The following is a description of a gene set: species: Mus musculus Mouse Gene Set: REACTOME_EUKARYOTIC_TRANSLATION_INITIATION Eukaryotic Translation Initiation, and this is the list of marker genes: Rps27l, Rpl35a, Rpl23a, Rpl3, Rpl12, Fau, Rps6, Rpl7a, Gm6525, Rpl18a, Rpl13a, Uba52, Rps14 (ribosomal protein S14), Rpl22l1 (ribosomal protein L22 like 1), Rps17, Rpl6, Rps27, Rpl39, Eif4ebp1, Rps7, Eif3k, Rps5, Rps9, Eif3j2, Rpl39l, Rpl37, Eif4a1, Rps24, Rpl27a, Rps11, Rpl18, Rpl34, Eif2s3x, Rps19, Rpl35rt, Eif3g, Rps27rt, Rps4x, Eif3f, Rpl36, Rpl24, Rps23, Eif3d, Rps29, Rps21, Rpl32 (ribosomal protein L32), Rpl31, Rps13, Eif3m, Eif1ax, Rps28, Eif2s1, Rpl23, Eif4g1, Eif2b2, Rpl27, Rpl9, Rpl10-ps3, Rpl36a-ps1, Rpl35, Rpl37a, Eif4a2, Eif5, Eif4h, Rps15a, Rpl30, Rplp1, Rpl5, Rplp0, Rps25, Rpl13, Eif4b (NCBI Gene Id 97980), Rps27a (ribosomal protein S27A), Eif3j1, Eif3h, Rpsa, Eif5b, Eif3i, Eif2b5, Eif2b4, Rpl11, Rps12, Eif4e, Rps26, Rpl19, Rpl14, Rpl10l, Rps8, Rpl3l, Rpl17, Eif2b3, Rps2, Rpl26, Rpl4, Eif3b, Rps20 (ribosomal protein S20), Rpl38, Eif3l, Rpl29, Rpl36al, Rpl28, Rps18, Eif3e, Rps10, Rpl7 (NCBI Gene Id 19989), Rps3, Rps16, Rpl22, Rplp2, Pabpc1, Rpl36a, Eif3c, Rps15 (ribosomal protein S15), Rpl15, Eif2b1, Eif3a, Rpl8, Uba52rt, Rpl21, Rpl10, Rps3a1, Eif2s2